The following is a description of a gene set: studied in species Homo sapiens The chemical reactions and pathways resulting in the formation of oligosaccharides, molecules with between two and (about) 20 monosaccharide residues connected by glycosidic linkages. Human Gene Set: GOBP_OLIGOSACCHARIDE_BIOSYNTHETIC_PROCESS, and this is the list of marker genes: LALBA, FUT7, ST6GALNAC5, FUT2, ST3GAL4, B3GALT1, MGAT2, FUT1, ST3GAL2, FUT4, B3GALT4, MPDU1, B3GALT5, FUT10, B4GALT1, B3GALT2, ST6GALNAC1 (NCBI Gene Id 55808), FUT5, ST6GALNAC6, FUT8, B3GALNT1, ST3GAL6 (NCBI Gene Id 10402), ST3GAL3, FUT3, FUT6, B4GALNT2, FUT9